Given this list of marker genes NTRK1, IRAK4, BTK, MYD88, MTHFD1, CFI, C2orf69, RFX5, NGF, here is a description of the gene set: Human Gene Set: HP_SEPTIC_ARTHRITIS Septic arthritis species: Homo sapiens